Given this list of marker genes HTR6, SUN1, EGFR, NR2E1, PEX5, CCDC141, MBOAT7, FBXO45, SLIT2 (NCBI Gene Id 9353), DIXDC1, NKX2-1, SRGAP2, RELN, RTN4, EFHC1, SUN2, ADGRG1, FUT10, POU3F3 (POU class 3 homeobox 3), LAMB1, DAB1 (DAB adaptor protein 1), PAFAH1B1, COL3A1, RAC1, FGF13 (fibroblast growth factor 13), ZMIZ1, GLI3, FOXG1, CDK5, CDK5R2, LRP8, PEX13, SOCS7, LHX6, DAB2IP (NCBI Gene Id 84635), RHOA, CTNNB1, SYNE2, DISC1, MDGA1, SRGAP2C, ARX, POU3F2, ROBO1 (NCBI Gene Id 6091), CDK5R1, P2RY12, PSEN1, WDR47, NDEL1, BMERB1, here is a description of the gene set: Human Gene Set: GOBP_CEREBRAL_CORTEX_CELL_MIGRATION The orderly movement of cells from one site to another in the cerebral cortex. species: Homo sapiens